Given this list of marker genes RACGAP1 (NCBI Gene Id 94651, Rac GTPase activating protein 1), CDK1, ECT2, SIRT2, KAT2B, AURKB, APC, CDCA8 (cell division cycle associated 8), HNRNPU, RCC2, CCNB1, KAT5, SPAG5, ZW10, BIRC5, BECN1, SIRT1, NEK2, KNTC1, CDC42, INCENP, ZWILCH, KNSTRN, here is a description of the gene set: Human Gene Set: GOBP_REGULATION_OF_ATTACHMENT_OF_SPINDLE_MICROTUBULES_TO_KINETOCHORE studied in species Homo sapiens Any process that modulates the frequency, rate or extent of the attachment of spindle microtubules to the kinetochore.